The following is a description of a gene set: species: Homo sapiens from publication Busconi L, Bauer JW, Tumang JR, Laws A, Perkins-Mesires K, Tabor AS, Lau C, Corley RB, Rothstein TL, Lund FE, Behrens TW, Marshak-Rothstein A (PMID 18025183) Human Gene Set: GSE6674_ANTI_IGM_VS_PL2_3_STIM_BCELL_DN We have previously shown that rheumatoid factors (RF) produced by Fas-deficient autoimmune-prone mice typically bind autologous IgG2a with remarkably low affinity. Nevertheless, B cells representative of this RF population proliferate vigorously in response IgG2a/chromatin immune complexes through a mechanism dependent on the sequential engagement of the BCR and Toll-like receptor 9 (TLR9). To more precisely address the role of both receptors in this response, we analyzed the signaling pathways activated in AM14 B cells stimulated with these complexes. We found that the BCR not only serves to direct the chromatin complex to an internal compartment where it can engage TLR9 but also transmits a suboptimal signal that in combination with the signals emanating from TLR9 leads to NF-kappa-B activation and proliferation. Importantly, engagement of both receptors leads to the upregulation of a group of gene products, not induced by the BCR or TLR9 alone, that include IL-2. These data indicate that autoreactive B cells, stimulated by a combination of BCR and TLR9 ligands, acquire functional properties that may contribute to the activation of additional cells involved in the autoimmune disease process. Genes down-regulated in B lymphocytes: anti IgM versus PL2-3 (Chromatin IC)., and this is the list of marker genes: SETD6, ID2, KAT2A, ARCN1, DPH5, IVNS1ABP, TAFA3 (NCBI Gene Id 284467), TUT1, IBTK, TPP2, RASA2, MRPL19, MAT2A, OSBP, FMNL3, LARS1, GABPB1, RPP25, MRI1, IPO9, YDJC, CDK6, DUSP4, KCTD13, NOC4L, LRP8, PCBP1, TAMALIN, MSTO1, DNAJC21, STT3A, MFSD2A, ERN1, AEN, FNIP2, TFDP1, ST3GAL4, HSD17B7, TPR, SHMT2, TUBA4A, KCNQ5, KCNAB2, ARF4, PIKFYVE, SRM, C19orf48P, UTP18, MORC2, LARP4, CAND1, HUWE1, LATS1, SF3B3 (NCBI Gene Id 9661), COPS7A, POLR1A, PRPF8, QNG1, LDLR, PANK3, ABCC1, HSPA4, SMYD2, IL2RB, ARMCX4, EFL1, UBA5, NOP2, TGFB1, ZDHHC21, TNF, EIF2S2, FAM185A, SLAMF7, C15orf48, ZC3HAV1L, GOLIM4, CRY1, ELMO2, DCUN1D2, CAD, ODC1 (ornithine decarboxylase 1), AFG2A, C5orf22, DNAJA2, MTAP, CALR, CNOT7, PLEKHA3, HSD17B12, ALDH18A1 (aldehyde dehydrogenase 18 family member A1), MRPL52, RMI2, GZMB, BLM, RASGRP1, MYBBP1A, NUP160, SEMA4D, NOL10, BDP1, PEX1, E2F3, SLC7A5, PLPP5, SPRED1, CLCN3, BMP2K, SEPTIN9, FASN, STRN3, UBQLN1, MAPRE1, HSP90B1, EEF1E1, KCNK5, TMEM68, LARP1, NPEPL1, PAXBP1, MLX, SLC25A15, CLPTM1L, TCOF1, SLC39A10, EIF4G3, EIF5A, AFG2B, XBP1, LYPLA2, VMA21, PALS2, RRN3, SEC24C, RCN2, TEX2, ZRANB2, AHCTF1, SQLE, XPO5, BDH1, NAF1, B3GALT6 (NCBI Gene Id 126792), WDR43, NEDD9, RBMXL1 (NCBI Gene Id 494115), HK2, ORC4, FARSB, RNF11, EPRS1, EIF3B, HSPA9, SEC16A, MRPL17, REXO2, DGKH, DCAF1, RABGGTB, PIM3, RARS2, YWHAG, DIMT1, FUBP1, DIS3, RANBP2, SLC39A6, DNAJC2, BTG3, NARS1, CA12 (carbonic anhydrase 12), BRIX1, SYPL1 (synaptophysin like 1), NSUN2, SENP6, TMEM147, NUP153, CDC37L1, CUL3, MYC, ZDHHC13, ACOT7, TMEM209, IL2RA, ETV5, BCLAF3, GEM, GFPT1, CHD1, KIAA1191, CD82, MTRR, XPOT, AARS1, SUZ12, GARS1, NUCB1, SIAH2, TARS1